The following is a description of a gene set: species: Homo sapiens Human Gene Set: KEGG_MEDICUS_REFERENCE_NOTCH_MESP2_SIGNALING Notch-MESP2 signaling. Pathway ID: N01481. Pathway type: Reference. Pathway class: nt06511 NOTCH signaling. Pathway Definition from KEGG: (NICD+RBPJ+TBX6) => MESP2 => (RIPPLY2,LFNG,EPHA4), and this is the list of marker genes: TBX6, LFNG, MESP2, RIPPLY2 (ripply transcriptional repressor 2), RBPJ, EPHA4